The following is a description of a gene set: studied in species Homo sapiens from publication Hill JA, Hall JA, Sun CM, Cai Q, Ghyselinck N, Chambon P, Belkaid Y, Mathis D, Benoist C (PMID 19006694) Genes down-regulated in comparison of regulatory T cell (Treg) versus conventional T cells. Human Gene Set: GSE13306_TREG_VS_TCONV_SPLEEN_DN CD4(+)Foxp3(+) regulatory T (Treg) cells originate primarily from thymic differentiation, but conversion of mature T lymphocytes to Foxp3 positivity can be elicited by several means, including in vitro activation in the presence of TGF-beta. Retinoic acid (RA) increases TGF-beta-induced expression of Foxp3, through unknown molecular mechanisms. We showed here that, rather than enhancing TGF-beta signaling directly in naive CD4(+) T cells, RA negatively regulated an accompanying population of CD4(+) T cells with a CD44(hi) memory and effector phenotype. These memory cells actively inhibited the TGF-beta-induced conversion of naive CD4(+) T cells through the synthesis of a set of cytokines (IL-4, IL-21, IFN-gamma) whose expression was coordinately curtailed by RA. This indirect effect was evident in vivo and required the expression of the RA receptor alpha. Thus, cytokine-producing CD44(hi) cells actively restrain TGF-beta-mediated Foxp3 expression in naive T cells, and this balance can be shifted or fine-tuned by RA., and this is the list of marker genes: CYB5R4 (NCBI Gene Id 51167), WIPF1 (WAS/WASL interacting protein family member 1), EVL, CD244, CXCR6 (C-X-C motif chemokine receptor 6), RCBTB2, ZFP36L2, PGM2L1, S100G, EPSTI1, TTC32, ARHGAP29, LYZL4, CDK6, DNMT1, SLC39A8, MBNL2, DSE, MPPED2, CDV3, LIMS4, OTUD1, IQCG, ERP29, ZFP14, ITM2B, CYP2S1, MED12L, TJP1, SFT2D2, CCR8, HS3ST3B1, PRR5, PLEKHA5, PTGR3, PDE7A, EXT2, CRTAC1, ACP3, SLC9A9, BCL2L13, DNAJC15, RPL3L, STAM2, SLC20A1, FYCO1, CFAP184, FGL2, CLEC6A, KIF3A, QSOX1, CGGBP1, MAP4K1, SNAI1, CXCR5, AGTRAP, ALDH3A2 (aldehyde dehydrogenase 3 family member A2), MNS1, SYTL2, CBY3, IL1R1, RIOX2, MFSD10, KIDINS220, GGT1, ZNF318, MAGEF1, MFSD6, COX6B1, H1-6, AMZ1, TBX5, ARRB2, FMR1, HACD2, XRCC4, ZFAND4, DHRS7, POMT2, CTDSP2, NNAT, AFP, AAK1, DUOX1, RYR1, BAAT, SLC52A3, PIM2, PADI2, ANKH, CYB561, COMMD8, SORL1, SATB1, EIF2AK3, PCBP2, GOLM1, SEPTIN6, NAP1L1, NFE2L1, PLTP, SESN3, LGALS3BP, DMP1, HSD17B1, RPA1, CHSY1, ABCB9, IL20RB, HSPA12A, FCGR2A, PCDH1, CDH1, TMEM232 (NCBI Gene Id 647447), NGLY1, GSAP, HMGN5, RAPGEF4, HIP1R, LSS, TREH, KCNE5, TEX9, CARD6, TDRP, SNHG7, HIRIP3, FAM174C, FBXL3, CHST12, LKAAEAR1, MYO1F, ST3GAL6, MCOLN2, LYPD6B, GPR171, TGFBR3, GRIK3, MICAL1, TGFBR2, ZNF471, AHR, SGSH (N-sulfoglucosamine sulfohydrolase), DSCC1, FAM78A, LNPEP, CPSF4, TLE4, ZDHHC2, SYNE1, SH3KBP1, SMCO3, POT1, TFAP4, COX10, CENPQ, FANCC, TTC9C, BLTP1, HAUS8, AHRR, BUB1B, ARHGAP39, FKBP5, RNF144A, H2BC5, EDEM3, CD177 (NCBI Gene Id 57126), SLCO3A1, CIB2 (calcium and integrin binding family member 2), MAN1C1, SMIM3, SIVA1, TRPC1, PHLDA2, TSPAN14, ATXN3, MARCKS, CYSLTR1, GNG2, SGMS1, ARHGEF18, EMB, KLRD1, MND1, SEMA6D, TMEM71, THEMIS, SLFN12L, SP4, CD2BP2, PORCN, BAIAP3, CD93, ST6GALNAC2, GNA11, ABCB7, PSAT1, DUBR